Given this list of marker genes NODAL, CDON, FGFR1, PLCH1, ZIC2, CRIPTO, DLL1, CSPP1, SIX3, DISP1, FGF8, GLI2, WNT3 (Wnt family member 3), TGIF1, SHH, SMCHD1, PTCH1, SMC1A, GAS1, STIL, STAG2, FOXH1 (NCBI Gene Id 8928), here is a description of the gene set: Single naris Human Gene Set: HP_SINGLE_NARIS The presence of only a single nostril. species: Homo sapiens